Given this list of marker genes PLEKHB1, ASAP1, GIPC2, MYCN, MYO3A, KCNC4, ZNF606, SLAMF1, KLF8, BBS9, CLUAP1, LDHB, HOXA11, FARS2, ADRA1D, CD2, ASXL1, CA6 (NCBI Gene Id 765), NRAP, KIF1C, TRMT61A, ACTL8, EML1 (EMAP like 1), STUM, HMGA2, LARP1, HAVCR1, RBMS3, RCAN3, SH2D3A, EPB42, BHLHE41, GPR183, NSUN5, RPL14, KPNA5, H2AC17, WNT7A, GIMAP4, EML4, STN1, TRMU, POU3F4, MALT1, IMPG2, EIF4A3, MAP3K14, PAPPA, CD6, AMMECR1, ZCWPW1, BAG3, CALM1, ITGA3, TPPP, CERK, HS3ST1, TNP2, KRTAP2-4, DNAJA2, EPHA2, SMR3B, COX7C, UBE2G2, ATXN1, B2M, HMX1, PTPRK, CCL2, INHBA, USP6NL, CCR9, CIDEA, CTDSP2, HES2, KCNV1, GPR20, PPM1H, ICOS, EFNA1 (ephrin A1), UGP2, THY1, SQOR, ST8SIA5, BSN, NOL3, CAMTA1, TNC, EIF2B5, RPL7A, OAZ3, EEF1B2, H4C7, PABPC3, HLA-B, MAGEA8, ARL4A, CISH (cytokine inducible SH2 containing protein), ANXA2P2, FOLH1B, CIRBP (cold inducible RNA binding protein), SCN8A, MAST4, HNRNPA1 (NCBI Gene Id 780920), SPINT3, PCYOX1L, PEBP1 (NCBI Gene Id 5037), PRSS1, PSG1, PLA2G3, LRRC2, TRPC7, DIP2C, EEF1A1, PKP4, PARD6A, ZDHHC11, H2BC5, C3orf36 (NCBI Gene Id 80111), TAF5L, PHACTR2, YIPF6, F8, CR1, CREB3L1, EBF2, ZC2HC1A, UBASH3A, CLIC5, OGN, RPL9, TAS2R3, IL11RA (interleukin 11 receptor subunit alpha), FKRP, PTEN (phosphatase and tensin homolog), SMAD3, ARMC1, OR3A3, SEL1L3, NDUFAF5, RPL3, FICD, CASP6, KDM3B, FAM171A1, MCL1, RPL23A, NEK11, TCTN3, BCL11B, EZR, RRAGC, MT4, KCNB1, SV2A, CELA2B, RPL27, PURG, CBFA2T2, ESRP2, TRIP13, SLC37A4, MTHFD1, CDX2, MYLIP, RPL39, HLA-A, SGSM2, IL26, PBXIP1, YARS2, AQP3 (NCBI Gene Id 360), B9D2, DAP3 (NCBI Gene Id 7818), LGI2, HSPB2, AGTR2, CCNT1, LTB, CASQ1, HAUS6, IL3, TPT1, TWNK, RPL37A, TAS2R14 (taste 2 receptor member 14), HABP4, KIF5C, DSG2, TPSD1, FBXO22 (NCBI Gene Id 80234), CD40LG, ZNF862, IL36G, DLGAP5, AMN, KMT2D, RPL4 (NCBI Gene Id 6124), here is a description of the gene set: species: Homo sapiens In the present study we used Affymetrix oligonucleotide microarrays to produce gene transcription profiles for the major leukocyte types in humans. This comprehensive dataset enabled us to not only establish which genes were expressed in each leukocyte type, but also which genes were expressed in each subset after activation. The used of a comprehensive dataset of gene profiles from all the major human leukocyte subsets enabled a novel and powerful means for identification of genes associated with single leukocyte subsets, or different immune paradigms. from publication Jeffrey KL, Brummer T, Rolph MS, Liu SM, Callejas NA, Grumont RJ, Gillieron C, Mackay F, Grey S, Camps M, Rommel C, Gerondakis SD, Mackay CR (PMID 16474395) Human Gene Set: GSE3982_EFF_MEMORY_CD4_TCELL_VS_NKCELL_UP Genes up-regulated in comparison of effective memory CD4 T cells versus NK cells.